Given this list of marker genes CPSF1, SYMPK, NUP85, NXF1, SEC13, NUP210, EIF4E (NCBI Gene Id 1977), NCBP1, NUP43, NUP160, NDC1, NUP50, SLBP, NCBP2, NUP133, NUP62, NUP37, NUP54, NUP98, NUP188, CPSF2, ALYREF, NUP42, NUP93, CPSF4, FIP1L1, NUP88, NUP153, CPSF3, AAAS, NUP35, NUP214, POM121, WDR33, RAE1, RANBP2, NUP58, NUP155, TPR, POM121C, SEH1L, NUP205, NUP107, here is a description of the gene set: Reactome Pathway: Transport of Mature mRNAs Derived from Intronless Transcripts part of: Transport of Mature Transcript to Cytoplasm species: Homo sapiens Transport of mature mRNAs derived from intronless transcripts require some of the same protein complexes as mRNAs derived from intron containing complexes, including TAP and Aly/Ref. However a number of the splicing related factors are lacking from the intronless derived mRNAs, as they required no splicing.